The following is a description of a gene set: species: Mus musculus Mouse Gene Set: REACTOME_PLATELET_AGGREGATION_PLUG_FORMATION Platelet Aggregation (Plug Formation), and this is the list of marker genes: Gp9, Rapgef4, Csk, Rapgef3 (NCBI Gene Id 70104), Gp5, Tln1, Itgb3, Sos1, Rasgrp1, Fgb, Col1a2, Rap1b, Pdpk1, Rap1a, Adra2c, Apbb1ip, Ptk2, Fga, Fn1, Ptpn1, Src, Vwf, F2, Syk, Gp1ba, Gp1bb, Bcar1, Crk, Itga2b, Fgg, Rasgrp2 (RAS, guanyl releasing protein 2), Shc1 (src homology 2 domain-containing transforming protein C1), Adra2a, Grb2, Adra2b, Col1a1, Akt1